The following is a description of a gene set: Human Gene Set: GOBP_RESPONSE_TO_INCREASED_OXYGEN_LEVELS Any process that results in a change in state or activity of a cell or an organism (in terms of movement, secretion, enzyme production, gene expression, etc.) as a result of a stimulus reflecting an increase in the level of oxygen. studied in species Homo sapiens, and this is the list of marker genes: MT-CYB, NOX1, SLC7A5, BNIP3, LCN2, CAT, CAV1, ATP6V0A2, FAS, ATP6AP1, ATG7, ATP6V1A, POLB, ATP6V0D1, TMEM199, COL1A1, CYP1A1 (cytochrome P450 family 1 subfamily A member 1), MT-ATP6, FOXO1, MMP2, KCNA5, HDAC2, CCDC115, ATP6V1G1, TXNRD2, SOD2, EPO